Given this list of marker genes Aldh1a1, mt-Cytb, Dut (NCBI Gene Id 93804), Rpl14, Igfbp7, Cox6c, Rps7, Rn7sk, Mif, Stx18 (syntaxin 18), Rps29, Rpl36a, Cdo1, Rps5, mt-Rnr2, Lbp, Gstm1, Rps21, Echdc2, mt-Nd4, Eef1b2, Sult1d1, Chchd10, Tmem176a, Kctd14, Trmt112, Rplp1, Gpx2, Plekhs1, Rps27, Stmn1, Rpl37a, Pigr, Atp5if1, Iah1, Lamp2, Gstm7, Serpinb11, Ldhb, Egfl6, Rpl32, Rbp1 (retinol binding protein 1, cellular), Gstm5, Id3, Rps15a, S100g, Mt1, Tgfbi, Siva1, Rps9, Rpl39, Ltf, Mt2, Rpl18, Rps28, Id2, Rpl18a, Tmem176b, Arg2, Rpl34, Ivns1abp, Rps12, Rpl26, Tceal9, Krtcap2, mt-Rnr1, mt-Nd1, Gstm2, Gas6, Ap1s3, Sbspon, Clu, Pcna, Rps24, Atp5pf, Rps26, Sox17, Rpl11, Prdx6, Mgp, Msx1, Mmp7, Tpt1, Cldn10, Ifitm1, Rpl38, Hint1, Ifitm3 (NCBI Gene Id 66141), BC048679, Mgst1, here is a description of the gene set: Mouse Gene Set: ZHANG_UTERUS_C2_REGENERATIVE_UP Representative genes of 3 sub-clusters of epithelial cells from publication Zhang L, Long W, Xu W, Chen X, Zhao X, Wu B (PMID 35669188) species: Mus musculus